The following is a description of a gene set: Human Gene Set: GSE7764_IL15_TREATED_VS_CTRL_NK_CELL_24H_DN Murine NK cells were compared at rest and following 24 hours of IL-15 stimulation for their mRNA expression profiles on the Affymetrix MOE430_2 microarray platform. Additional comparators included resting bulk splenocytes. from publication Fehniger TA, Cai SF, Cao X, Bredemeyer AJ, Presti RM, French AR, Ley TJ (PMID 17540585) species: Homo sapiens Genes down-regulated in comparison of NK cells treated with IL15 versus untreated NK cells., and this is the list of marker genes: PTPDC1, GLUL, SPO11, SMARCD3, CNRIP1, SAMTOR, FHIP1B, ATP10D, S1PR1, TMEM71, XDH, WFIKKN2, ACP5, ZYG11B, PTH1R, VSIR, MXD1, ALDH1B1, CTSE, DHRS3, MARCKS, BCL11B, FOXO4, AFMID, CRHR1, TCP11L2, AS3MT (NCBI Gene Id 57412), FCGR2B, MAG, TMEM14A, ATOSA, RBAK, AR (androgen receptor), PTGS1, EPHA1, CMA1, ACSS1, NAP1L5, L3MBTL3, KIF1B, NPY1R, KLF12, TMTC1, NRCAM, ZNF274, KLF2, ARHGEF18, CD200R1L, KCNIP3, KCTD18, CREB3L2, ABCB1, SUSD1, NHSL2, IMPACT, BAZ2A, KANSL1L, MARCHF3, RICTOR, TRIP4, ZER1, IL7R, STRA8, G0S2, PDE5A, TSGA10, TULP4, KLHL29, CARNS1, GSAP, KDM3B, ZNF493, ATXN7, CAMK2D, NCALD, NOXO1, ATP6V0A1, SERPINA4, STX17, UPB1, GNB5, SYNE1, CEP164, CX3CR1, USP17L2, CSRNP2, TET2, RFX5, PSD2, PCYT1A, KDM7A (lysine demethylase 7A), SLAMF6, CPNE7, B3GNT5 (NCBI Gene Id 84002), PTTG1, KCTD12, ALDH3B1, ABTB3 (ankyrin repeat and BTB domain containing 3), RBM11, ZBTB20, FOS, CRACDL, POU5F2, LEF1, AKAP5, CAV1, MACIR, TMEM242, USP33, CITED2, FHIT, CBLN1, PLXNC1, CPEB2, ABCG1, ZBTB10, HIVEP2, CXCR4 (C-X-C motif chemokine receptor 4), NOSTRIN, DCDC2B, PLCB4, PCMTD1, ACSS2, TOB1, KRBA1, APBB1IP, DNAH8, RSAD2, ELOVL7, AGO4, GPRC5A, PHACTR3, SELP, ITGA4, LINC01160, ICA1L, CYP39A1, FOXO3, ZIC4, S1PR5, WLS, PCMTD2, FAM219A, GNAZ, MYBPHL, C1QL3, UTRN, H2BC3, SERPINI1, MSR1, ARSG, PLVAP, LYST, PHYHIPL, CFAP210, COX6A2, MED13L, KLF3, ESYT2, SLC38A9, NCK2, KRTAP11-1, RAB11FIP5, PRKCA, APOBEC2, TFPI2, APOE, HOXB4, ABCA1, IQSEC3, ANKRD50, YAP1, MLLT3, DDIT3, MIR99AHG, NPAS2, ACAP2, BACH2, OXR1, TET1, TRPS1 (NCBI Gene Id 7227), FBXO32, TSPAN32, CREBBP, TTC12, IFIH1, IFIT1, RAB12, NCKAP5L, PRKCE, MPEG1, RIPOR2, IRF7, RRM2B, P2RX4, EPAS1, ARHGAP6, CPNE5, EPS8L1, TSKS